The following is a description of a gene set: Any process that modulates the frequency, rate or extent of Rab protein signal transduction. Mouse Gene Set: GOBP_REGULATION_OF_RAB_PROTEIN_SIGNAL_TRANSDUCTION species: Mus musculus, and this is the list of marker genes: Madd, Dennd4c, Dennd4a, Dennd4b, Dennd3, Rab3gap1, Sgsm3, Dennd1a